Given this list of marker genes Defb1, Defb18, Defb43, Defb14, Defb28, Tlr2, Defb30, Defb42, Ccr6, Defb25, Defb47, Defb36, Defb48, Defb21, Defb4, Tlr1, Defb19, here is a description of the gene set: species: Mus musculus Beta defensins Mouse Gene Set: REACTOME_BETA_DEFENSINS